The following is a description of a gene set: Protein localization species: Homo sapiens Human Gene Set: REACTOME_PROTEIN_LOCALIZATION, and this is the list of marker genes: TIMM10B, TIMM8A, ZFAND6 (NCBI Gene Id 54469), SLC27A2, APP, TIMM50, PEX3, PEX7, PEX19, PMPCB, PEX14, COQ2, FIS1, PEX11B, SLC25A13, PIPOX, MPV17, COA4, TIMM8B, HMOX1, HSD17B4, ATP5MC1, BAAT, OTC, BAG6, UBE2D3, UBA52, TIMM10, PEX2, TIMM17A, RPS27A, ATP5F1B, GFER, PAOX, CAT, IDH3G (isocitrate dehydrogenase (NAD(+)) 3 non-catalytic subunit gamma), VDAC1, STX1A, GRPEL1, ECI2 (NCBI Gene Id 134779), FXN, PRNP, ABCD2, PECR, UBB, IDH1, TIMM13, TIMM9 (translocase of inner mitochondrial membrane 9), HMGCL, ALDH3A2, TOMM5, DDO, SLC25A12, HSPA9, ACOX1, EMD, DNAJC19, HAO1, TOMM7, CMC4, TIMM22, CS, HSCB, TIMM21, OTOF, VAMP2, AMACR, COX19, GDAP1, TIMM44, PEX12, SLC25A17, PMPCA, PEX6, ATP5F1A, ACO2, CHCHD10, GET4, TAFAZZIN, NDUFB8, ACAA1, EHHADH, VAPA, SAMM50, DECR2, SLC25A4, SEC61G, AGPS, PHYH, TYSND1, IDE, PEX26, GNPAT (NCBI Gene Id 8443), UBC, DHRS4, ATAD1, TOMM22, NUDT19, UBL4A, SEC61B, ABCD1, ACBD5, SLC25A6, PEX5, ACOT8, UBE2D2, HAO2, PEX10, TOMM70, GRPEL2, GET3, CHCHD3 (NCBI Gene Id 54927), CMC2, CROT, DAO, ACOX3, HSPD1, ACOX2, SERP1, ACOT4, PITRM1, PEX13, GET1, MTX1, PXMP4, PAM16, NOS2, PXMP2, PEX1, BCS1L (NCBI Gene Id 7856), EPHX2, PEX16, ABCD3, CYB5A, TOMM40, ACOT2, COA6, AGXT, STX5, ECH1, TIMM23, TOMM20, COX17, CAMLG, NUDT7, HACL1, USP9X, CHCHD2, CHCHD5, TIMM17B, CHCHD7, CHCHD4, LONP2, LDHD, SGTA, UBE2D1, CRAT (NCBI Gene Id 1384), SCP2, UBE2J2, MTX2 (metaxin 2), GSTK1 (NCBI Gene Id 51064), TOMM6, CYC1, MLYCD